The following is a description of a gene set: studied in species Mus musculus Mouse Gene Set: IRITANI_MAD1_TARGETS_DN from publication Iritani BM, Delrow J, Grandori C, Gomez I, Klacking M, Carlos LS, Eisenman RN (PMID 12234922) Genes down-regulated by overexpression of MAD1 in primary thymocytes from RAG2 knockout mice. Activated lymphocytes must increase in size and duplicate their contents (cell growth) before they can divide. The molecular events that control cell growth in proliferating lymphocytes and other metazoan cells are still unclear. Here, we utilized transgenesis to provide evidence suggesting that the basic helix-loop- helix-zipper (bHLHZ) transcriptional repressor Mad1, considered to be an antagonist of Myc function, inhibits lymphocyte expansion, maturation and growth following pre-T-cell receptor (pre-TCR) and TCR stimulation. Furthermore, we utilized cDNA microarray technology to determine that, of the genes repressed by Mad1, the majority (77%) are involved in cell growth, which correlates with a decrease in size of Mad1 transgenic thymocytes. Over 80% of the genes repressed by Mad1 have previously been found to be induced by Myc. These results suggest that a balance between Myc and Mad levels may normally modulate lymphocyte proliferation and development in part by controlling expression of growth-regulating genes., and this is the list of marker genes: Gm10275, Pold1, Cpsf3, Eef2, Mybbp1a, Srm, Mcm6, Babam1 (NCBI Gene Id 68251), Ass1, Npm1, Rpl5-ps1, Eef1g, C1qbp, Gpam, Gas5, Ppa1, Mettl26, Uqcrc1, E2f8, Ipo5, Dtd1, Slc16a1 (solute carrier family 16 (monocarboxylic acid transporters), member 1), Rpl18, Apex1 (NCBI Gene Id 11792), Hspa9, Lonp1, Eif1a, Rad23b, Rpl22, Gpi1, Cdk1, Mrps18b, Slc5a6, Nme2, Ahcyl (NCBI Gene Id 98500), Dut, Dctpp1, Rpl13 (NCBI Gene Id 270106), Wdr74, Cad, Fbl, Hnrnph2, Gga2, Rpsa, Rars1 (NCBI Gene Id 76827), Rpl10a